The following is a description of a gene set: species: Mus musculus Mouse Gene Set: GOBP_PURKINJE_MYOCYTE_TO_VENTRICULAR_CARDIAC_MUSCLE_CELL_COMMUNICATION The process that mediates interactions between a Purkinje myocyte and its surroundings that contributes to the process of the Purkinje myocyte communicating with a ventricular cardiac muscle cell in cardiac conduction. Encompasses interactions such as signaling or attachment between one cell and another cell, between a cell and an extracellular matrix, or between a cell and any other aspect of its environment., and this is the list of marker genes: Scn5a, Ryr2, Scn1b, Gja5, Trpm4